The following is a description of a gene set: Human Gene Set: GSE5542_UNTREATED_VS_IFNG_TREATED_EPITHELIAL_CELLS_6H_DN Type I and type II interferons (IFNs) bind to different cell surface receptors but activate overlapping signal transduction pathways. We examined the effects of a type I IFN (IFN-acon1) and a type II iFN (IFN-g1b) on gene experession in A549 cells and demonstrate that there is a common set of genes modulated by both IFNs as well as a set of gene specifically regulated by each, reflecting the activation of different signaling pathways. In particualr, IFN-g induced many more genes of the signaling pathways, apoptosis, and cytokine interactions than did IFN-a. Even with genes induced by both IFNs there were distinctive quantitativive differences in expression. IFN-g1b plays a major role in the induction and regulation of the complement pathway. Previous work has shown a synergistic antivral and antiproliferative effect of type I and type II IFNs in cell culture and in the treament of tumors in mice. We demonstrate that a majority of genes showed and additive effect of IFN-acon1 and IFN-g1b, but a subset of gene is synergistically induced; these incluce ISG10, MX2, OAS2, and other genes known to be involved in the antiviral response, TRAIL (TNFSF10) and caspases involved in apoptosis and chemokine genes RANTES, CXCL10, and CXCL11. Greater than additive transcription of some of these genes in the presence of both IFNs was confirmed by real-time kinetic RT-PCR. Elevated induction of many of these genes may be sufficient to explain the synergistic antiviral and antitumor effects of this combination of IFNS in vivo. studied in species Homo sapiens Genes down-regulated in epithelial cells (6h): untreated versus IFNG. from publication Sanda C, Weitzel P, Tsukahara T, Schaley J, Edenberg HJ, Stephens MA, McClintick JN, Blatt LM, Li L, Brodsky L, Taylor MW (PMID 16800785), and this is the list of marker genes: FOXP4, OSBPL7, SPEF2, ZFY, HEG1, NIBAN1, MBNL3, ACBD5, CTNNA1, OSTF1, REEP5, APOBEC3G, SPIN4, CNNM3, CYTH3, UBN2, CUL3, DENND1B, ABI3, NEDD9, SASH3, C1RL, KIF1C, PTK2B, GGA2, MYO5A, DENND1A, ALOX5AP, PTPN22, BAZ2B, HEATR5A, EHD3, FCHO2, PTPRM, SRGN, CLSTN1, NCBP3, CLSTN3, UBE2L6, SMAD5, PPP1R16B, ANKS1A, RASAL3, MAN1A1, GNAO1, YWHAH, NR3C1, NPC1, LCP2, GNAS, TPRG1, FYCO1, NF1, NCALD, TBXAS1, GFPT2, CACNB1, ANXA5 (annexin A5), SLC23A2, TBC1D2B, PTPN9, ATP10D, TACC1 (transforming acidic coiled-coil containing protein 1), SNX10, NHLRC2, AIM2, ATP2A3, SNX33, SPTY2D1, PLEKHA2, B4GALT5, IL15, EIF4EBP2, CMTM3, TGFB1, PLCD1, SNX24, SCARNA17, MYO1F, MAP2K2, ULBP3, ENPP5, MXD4, UBE2Q2P1 (NCBI Gene Id 388165), XPR1, LYN, RMDN2 (NCBI Gene Id 151393), MRPL10, NAA38, MIR199A1, KIAA1671, AUTS2, RNF166, ERMP1, MYH9, MAP3K5, DLG5, DUSP10, ARHGAP35, CHD9, SLFN11, CRADD, PIP4K2A, PPP4R1, PIK3AP1, APOBEC3D, ATXN1 (ataxin 1), GABARAPL1, MAF, ZNF532, CDC73, WDFY1, TMX4, TNFRSF1A, NBEAL2, NCKAP1, TCF7L2, EPS15, PIEZO1, YAF2, SLFN12L, ACTN4, BMPR1A, DLG1, TBC1D5, DCAF15 (DDB1 and CUL4 associated factor 15), MICAL2, ABCA2, CMIP, BLOC1S3, PLEKHA5, MYBL1, GLCCI1 (NCBI Gene Id 113263), ANKRD13D (NCBI Gene Id 338692), CCDC92, BMAL1 (NCBI Gene Id 406), ARFGAP1 (NCBI Gene Id 55738), RNF19A, MICB, CHST11, TOX, ST3GAL4, ITGAV, SLC6A6 (NCBI Gene Id 6533), TCIRG1 (NCBI Gene Id 8845), ARF3, RALGPS1, PLXND1, SLC1A5, LCP1, NKG7, DUSP2, NFAT5, CD99, UEVLD, CD58, PPP2R2B, GRAMD1C, CCL5, LZTR1, ARHGAP10, PPP2R5C, ARL15, FYN, LPGAT1, SGPL1, DNAJC1, CCR5, VIPR2, CFLAR, AGO4, B3GALT4, ACBD3, PLEKHF1, MIRLET7F2, TMED8, KLRG1, ECPAS, KLRB1, TM9SF1, EIF4E3, ADCY9, THBS1, BCL6, AOAH, SLC25A43, HIP1, GAB3, SNRNP200, RDX, GALM, CLTC, DTD1, HLA-DRB5, KATNAL1, PIK3CG, ODF2L, AKAP13, SLFN13, PHACTR2